Given this list of marker genes TRPV2, EGF, PRNP (prion protein (Kanno blood group)), SEMG1, PPP3R2, CASR, PLPP4, PKD2, STC1, ISL1, SLN, SPINK1, PDGFB, LGALS3, STRIT1, TRIM27, HOMER1, CCL2, PPP3R1, CRH, PPP3CA, HES1, AKAP5, PPP3CB, CXCL12, SLC30A1, CAV3, MS4A1, P2RX5, UCN (urocortin, NCBI Gene Id 7349), GRM6, TRPV3, CASK, MIR34A, MIR208A, GCG, FCRL3, WNK3, P2RX1 (purinergic receptor P2X 1), CTNNB1, PLN, PDGFRB, KCNN4, CCL3, ATP2C2, FYN, PPP3CC, EPPIN, MIR208B, MIR200C, here is a description of the gene set: studied in species Homo sapiens Any process that modulates the rate, frequency, or extent of the directed movement of calcium ions into a cell or organelle. Human Gene Set: GOBP_REGULATION_OF_CALCIUM_ION_IMPORT